Given this list of marker genes TIFA, MAFF, SAMD4B, RAB20, NR4A3 (nuclear receptor subfamily 4 group A member 3), GDF15, UBE2E3, RBM7, GSAP, MARCKSL1, BCL2A1, PIM1, PTPN3, ADAM17, HLA-B, HCK, CX3CL1, TLR2, NFKB2, GBP4, IL1RN, DAPP1, GLIPR1, CXCL9, ARID2, NCK1, DUSP2, HTR7, SLC11A2, ACSL1, CSF2RB, RNF19A, LTA, TAMALIN, ATF7, NR4A1, TNFAIP2, N4BP1, PTPN12, FNBP1L, GADD45B, DNAJC21, ACOD1, CD69, STAT5A, LAMC2, EBAG9, BCOR, CD40, EGR3, EPOP, TGIF1, CXCL10, ZNF516, UBXN2A, RAPGEF2, FOXO1, SAMSN1, CX3CR1, TNFAIP8L1, SLC2A6, ERBB2 (erb-b2 receptor tyrosine kinase 2), ZFP36L1, EHD1, IFNAR1, IL1A, CEP350, IER3, MAP3K8, AK2, CD86, SLC5A3, FGR, SPIB, NFKBIE, CEBPB, KPNA3, HDC, IL4I1, MYL4, CXCL16, DDHD1, PLK2, NAB1, CISH, SEMA6D, PSTPIP2, PLEKHO2, SLC35D3, NIBAN3, FOXP4, SMU1, CDKN1A, GFPT1, CASS4, ERRFI1, ZC3H12C, DYRK2, DUSP5, CCRL2, RALGDS, SOWAHC, RBM22, PRDM1, KDR, ESF1, ICAM1, OSM, IL12B, NR4A2, RBBP8, AEBP2, SPIC, PDE4DIP, TNIP1, TAGAP, GPR65, DPF2, CSRNP1, DUSP1, IL6, RELB, TRAF1, GPR132, FBRS, CXCL2, TRAF3, MCOLN2, ARG2, SNHG3, CXCL1, SAA1, FLRT3, RRAD, SPATA13, PHLDB1, PSPC1, ETS2, CFLAR, HERPUD1, IER2, RFX5, IFRD1, PTGIR, CD83, DCUN1D5 (NCBI Gene Id 84259), SKIL, TNFSF9, ADORA2B, CCL22, GPR84, SRP54, UBE2F, BTG2, HIVEP3, SOD2, KIAA0040, ST3GAL1, GCH1, REST, PDGFB, PIK3R5, ARHGAP31 (NCBI Gene Id 57514), SERPINB9, SMS, CASP4, FAM177A1, MCL1, NLRP3, IGSF6, JUNB, HVCN1, NFE2L2, DTX4, DKKL1, PTGER4, ZFP36, NFKBIZ, RELA (NCBI Gene Id 5970), UBE2A, EIF6, KDM6B, FAM83E, SOCS3, IRF1, UAP1, SLAMF7, IL2RG, PNRC1, CCL17, FAS, CD14, ITGA5, DCBLD2, PTPRO, TSPAN33, BCL3, LCA5L, VASP, AREG, here is a description of the gene set: Genes down-regulated in bone marrow-derived macrophages with NFAT5 knockout: control versus stimulated with LPS. Human Gene Set: GSE26343_UNSTIM_VS_LPS_STIM_NFAT5_KO_MACROPHAGE_DN Gene expression from WT and NFAT5 KO primary macrophage cultures. from publication Buxadé M, Lunazzi G, Minguillón J, Iborra S, Berga-Bolaños R, Del Val M, Aramburu J, López-Rodríguez C (PMID 22312110) studied in species Homo sapiens